Given this list of marker genes GFUS, FUT1, PLPP3, RRAS, LEF1, RIN2, CEACAM6, here is a description of the gene set: Any process that activates or increases the frequency, rate or extent of endothelial cell-matrix adhesion via fibronectin. studied in species Homo sapiens Human Gene Set: GOBP_POSITIVE_REGULATION_OF_ENDOTHELIAL_CELL_MATRIX_ADHESION_VIA_FIBRONECTIN